The following is a description of a gene set: Human Gene Set: BARRIER_COLON_CANCER_RECURRENCE_DN We have assessed the possibility to build a prognosis predictor (PP), based on non-neoplastic mucosa microarray gene expression measures, for stage II colon cancer patients. Non-neoplastic colonic mucosa mRNA samples from 24 patients (10 with a metachronous metastasis, 14 with no recurrence) were profiled using the Affymetrix HGU133A GeneChip. Patients were repeatedly and randomly divided into 1000 training sets (TSs) of size 16 and validation sets (VS) of size 8. For each TS/VS split, a 70-gene PP, identified on the TS by selecting the 70 most differentially expressed genes and applying diagonal linear discriminant analysis, was used to predict the prognoses of VS patients. Mean prognosis prediction performances of the 70-gene PP were 81.8% for accuracy, 73.0% for sensitivity and 87.1% for specificity. Informative genes suggested branching signal-transduction pathways with possible extensive networks between individual pathways. They also included genes coding for proteins involved in immune surveillance. In conclusion, our study suggests that one can build an accurate PP for stage II colon cancer patients, based on non-neoplastic mucosa microarray gene expression measures. from publication Barrier A, Roser F, Boëlle PY, Franc B, Tse C, Brault D, Lacaine F, Houry S, Callard P, Penna C, Debuire B, Flahault A, Dudoit S, Lemoine A (PMID 17043639) Down-regulated genes from the 70-gene prognosis predictor for stage 2 colon cancer, based on non-neoplastic mucosa gene expression profiles. species: Homo sapiens, and this is the list of marker genes: CTSA, STAT2, TLE5, ASB13, BSG (NCBI Gene Id 682), CDK10, NUCB1, SPPL2B, BTBD2, NDFIP1, CD24, FOXJ3, TSPAN7, CITED2, KCNAB1, EPPK1, ACOT11, PFKL, ARHGAP33